Given this list of marker genes ACOT13, MLXIPL, APLP2, CLIP4, BTK, AGPAT4, SHTN1, ABHD11, EHD4, RRAGD, HAGH, SLC8B1, LGALS3, DAPK1, PTPRE, IFI30, APOO, CTTN (cortactin), GPNMB, BLVRB, TLE4, HMG20B, DYSF, NPL, PI4K2A, CTSO, ACSL3, FTL (NCBI Gene Id 93315), ZCCHC14, PRCP, GABARAP, MNDA, CAVIN1, APP, PLBD1 (NCBI Gene Id 79887), METTL1, CLIC4, CEP170, LMBR1L, POR, ATG3, NUPR1, FRAT1, GLUL, MIPEP, CD63, LAMP2, FCER1G, HEATR3, CDA, CCR1, TNS3, IL6R, DOCK1, FCGR2C, FADS1, HLA-DRA, RAB13, PDLIM5, ZNF468, FBP1, ZEB2, CBLC, CD81, RNF13, HLA-B, ST3GAL5, SLC11A1, TBXAS1 (NCBI Gene Id 6916), PLEKHB1, CCK, TRPM4, SYK, MILR1, CMKLR1, SDCBP, TCF7, ATP6AP1, TLR1, WDR43, EPB41L3, HK3, GCA, MAN2B1, MPP1, LIPA, MOB3B, SGPL1, SOAT1, IDH1, ACVR1B, CTBP2, CRELD1 (NCBI Gene Id 78987), DAB2, TLE2, PTOV1, CD9, HEXA, ALDH2, C3, ECHDC3, DHX58, NCKAP1L, VAMP3, SLC22A1, PSAP, VCL, ACOX3, THEMIS2, SLC31A1, IL7R, STX11, PKD2L1, CD209, ZNF185 (zinc finger protein 185 with LIM domain), FHIT, RHOQ, VPS37C, S100A8, ALAS1, MEGF9, ITGAM, CREG1, NCF2 (neutrophil cytosolic factor 2), SLC47A1, RTN1, SLC27A3, TRPV2, SLC2A6, SLC2A9, ATP6V1E1, STARD8, NPTN, P2RY6, NINJ1, FES, ZDHHC7, GABARAPL1, FZD2, STEAP3, ADA2 (NCBI Gene Id 51816), LMO2, CD33, F11R, LYZ, INSR, TLR8, HSPA12A, KIAA0930, CLEC11A, LMNA, ARHGEF10L, SAV1, RAB31, NR1H3, IFNGR1, TSPAN3, SCAMP1, ITGA5, RIN1, ITGB2, CTSH, CAMSAP2, DSC2, TLR2, NRP1, ITGAX, SPP1, AKAP1, RPS6KA2, HSPA6, CNNM4, COL8A2, APOBEC1, VTN, CLEC10A, S100A13, NDRG1, SCPEP1, BCAP31, SLC12A7, CLCF1, LDLRAP1, CTSZ, HLA-DMA, NPC2, MS4A4A, TSPO, TNFAIP6, CLDN7, FPR2, PYGB, SPART, MRC1, ATG9A, FGL2, GRN, C1QA, CAPG, S100A9, here is a description of the gene set: Human Gene Set: GSE24634_TEFF_VS_TCONV_DAY10_IN_CULTURE_DN Genes down-regulated in comparison of untreated CD25+ T effector cells at day 10 versus untreated CD25- T cells at day 10. from publication Prots I, Skapenko A, Lipsky PE, Schulze-Koops H (PMID 21347372) CD25+ regulatory T cells develop in the thymus (nTregs), but may also be generated in the periphery upon stimulation of naive CD4 T cells under appropriate conditions (iTregs). The mechanisms that regulate the generation of peripheral iTregs are largely unknown. We used microarrays to gain insights into the molecular program of extrathymic Treg development. species: Homo sapiens